Given this list of marker genes Ambp, Adgre5, Mdk, Rtn4rl1, Ptprs, Agrn (agrin), Impg1, Ptn, Dpysl3, Rtn4r, here is a description of the gene set: Mouse Gene Set: GOMF_CHONDROITIN_SULFATE_BINDING species: Mus musculus Binding to chondroitin sulfate, a glycosaminoglycan made up of two alternating monosaccharides: D-glucuronic acid (GlcA) and N-acetyl-D-galactosamine (GalNAc).